The following is a description of a gene set: Human CD14 positive monocytes were purified from healthy volunteers’ blood and cultured in vitro for 4, 12, 24, 72 hours. While culturing, macrophages were activated alternatively with interleukin-4 (IL-4 100 ng/ml) or classically with interferon-gamma (IFNg 100 ng/ml)+tumor necrosis factor (TNF 50 ng/ml) or left without activation. Simultaneously, macrophages were also treated with vehicle (DMSO:ethanol) or 1mM synthetic PPARg agonist, Rosiglitazone. We used Affymetrix microarrays (U133Plus 2.0) to analyze activation and PPARg-induced gene expression changes. from publication Szanto A, Balint BL, Nagy ZS, Barta E, Dezso B, Pap A, Szeles L, Poliska S, Oros M, Evans RM, Barak Y, Schwabe J, Nagy L (PMID 21093321) Genes up-regulated in macrophages (12h): rosiglitazone and IL4 versus rosiglitazone. Human Gene Set: GSE16385_ROSIGLITAZONE_IL4_VS_ROSIGLITAZONE_ALONE_STIM_MACROPHAGE_UP studied in species Homo sapiens, and this is the list of marker genes: C11orf91, ERBB3, SGSM1, GLT8D2, NOVA2, SYNPO2L, ABLIM3, CH25H, POSTN, CHAD, MED7, ASB17, NCEH1, USP2, RHBDL2, CCDC167, G6PC2, WWTR1, GCSAM, TMEM167A, CYP51A1, TBL1XR1, ZDBF2, F2R, TLR2, HES1, ESRP1, LENG9, KCNN1, REEP2, DCLRE1C, PTGDR2, NOSTRIN, KLHL24, NGFR, OSBPL2, CNST, STAC2, PTPRB, AANAT, SFXN3, FLRT2, COL9A3, SLC26A8, ADCY2, FAM228A, ZNF423, TNFRSF13C, NAP1L3, SPINT1, GJC3, RBMXL1, TENT5C, ENDOD1, CRHR2, VDR, GSDME, ASB9, TNS3, IQGAP1, SULT6B1, ZNF264, SLCO4A1, FTMT, PROKR2, GUCD1, PAPOLB, CXXC5, SKIL, RUFY1, PDE3A, ZFP37, KCNAB1, AJM1, SIPA1L2, ALDH8A1, TTC39B, CIDEA, TMEM86A, SIVA1, RHPN1, PKD2L1, LPIN2, TRAF2, AGMO (NCBI Gene Id 442510), CC2D2B, KLHL6, BACE2, GABRG2, GSTO2, BMP7, CUZD1, FAM210B, GOLM1, TNKS, SMIM5, EGFL6, HTRA3, S1PR1, BMAL1, HABP2, CLDN1, OTOP3, SLC1A2, S100A5, CHRNA1, TCF19, NINJ1, MYO7B, AFF2, FAHD2A (fumarylacetoacetate hydrolase domain containing 2A), KLHL30 (NCBI Gene Id 377007), CMA1, NTRK3, UBASH3B, KCNN4, BHLHE40, PCSK6, RXRG (retinoid X receptor gamma), CALCR, ATOSA, FAM241B, FHOD1, SLCO5A1, LYST, NOL4, FUT2, SLC45A3, HOPX, LAIR1, SNX9, KCNT2, SIGLEC7, ABCG1, SGSH, TBC1D2, MED12L, RGS2, SLC18A1, SPMIP10, SCARB2, ITGB6, COL6A2, ASB6, NR2C2, ATP6V0A4, FRMPD3, EXTL3, ZBTB11-AS1 (ZBTB11 antisense RNA 1), OMP, EDA (NCBI Gene Id 90878), CIMAP1B, MAP7D2, TEKT3, SPECC1, PRNP, PLAAT3, TGFBR1, PDCD1LG2, GLI1, SDHAF2, EPS8L3, JUP, CCNE1, GPX5, MTHFSD, PRRG3, PALD1, ENTPD2, ERN2, TBC1D9, RILPL1, KCND1, CEP83-DT, CARD6, CYP11A1, BLCAP, STK38, MTSS1, LACTB, TCTN3, RNF146, PRMT8, ADAMTS6, IGDCC3, AZIN2, ANKRD54, KCTD14, ANO3, GBP6, INA, ZKSCAN5, PRKCH, HNRNPA0, CYFIP1 (cytoplasmic FMR1 interacting protein 1), KBTBD3, CRMP1 (collapsin response mediator protein 1), CIMIP1, P2RY12, ZNF750